Given this list of marker genes Grip2, Lrrc7 (leucine rich repeat containing 7), Myo5b, Scrib, Gripap1, Vps35 (VPS35 retromer complex component), Grip1, Arhgap44, Rab8a, Rab11a, Nsg1, here is a description of the gene set: The directed movement of neurotransmitter receptor from the endosome to the plasma membrane in transport vesicles. species: Mus musculus Mouse Gene Set: GOBP_NEUROTRANSMITTER_RECEPTOR_TRANSPORT_ENDOSOME_TO_PLASMA_MEMBRANE